Given this list of marker genes Tlr4, Ticam2, Cd274, Ticam1, Cd300lf, Tlr6, Irf3, here is a description of the gene set: The series of molecular signals initiated by a ligand binding to a toll-like receptor where the TRIF adaptor mediates transduction of the signal. Toll-like receptors directly bind pattern motifs from a variety of microbial sources to initiate an innate immune response. Mouse Gene Set: GOBP_TRIF_DEPENDENT_TOLL_LIKE_RECEPTOR_SIGNALING_PATHWAY species: Mus musculus